Given this list of marker genes Hs3st4, Gpc3, Ext1, Hs3st3a1, Sdc3, Hs3st1 (NCBI Gene Id 28009), Hs6st2, Gpc2, Ndst1, Ndst2, Sdc1, Gpc4, Hs6st1 (NCBI Gene Id 50785), Ext2, Agrn, Hs3st6, Hs2st1, Sdc4, Ndst4, Hs3st3b1, Gpc5, Gpc6, Slc35d2, Ndst3, Hs3st5, Hs3st2, Hs6st3, Sdc2, Gpc1, here is a description of the gene set: Mouse Gene Set: REACTOME_HS_GAG_BIOSYNTHESIS studied in species Mus musculus HS-GAG biosynthesis